The following is a description of a gene set: studied in species Homo sapiens from publication Chen Y, Wang X (PMID 31504780) Genes predicted to be targets of miRBase v22 microRNA hsa-miR-1208 in miRDB v6.0 with MirTarget v4 prediction scores > 80 (high confidence targets). Human Gene Set: MIR1208, and this is the list of marker genes: POLR1F, TMED6, ADD3, CHMP2B (charged multivesicular body protein 2B), GRIA4, BTBD3, PRKAB1, YTHDF2, IRS2, PAQR9 (progestin and adipoQ receptor family member 9), IL5RA, FNDC3A, PPP1R10, PPP2R2A, ZFR, AFF3, SECISBP2L, BACH2, OXR1, BTBD10, LINC03040, GPM6B, DISC1, ZKSCAN1, ZC3H13, HERPUD2, GNB4, IRF6, ZIC3, TYR, TMEM170B, PACSIN2, HAPSTR1, ZDHHC7, ROBO2 (NCBI Gene Id 90370), CRTAP, NUDCD1, NFATC3, BCLAF3, ADRA1A, AP1G1, FANCA, JKAMP, ZNF280D, CDADC1 (cytidine and dCMP deaminase domain containing 1), USP45, TCEAL4, HIC2, CNTRL, SLC24A2, SRSF10, DHFR2, GORASP1, CASP14, ARHGEF6, SLC25A44, AGPAT4, TMEM209, SPRY3, EIF2S2, KIF3A, TBX1, PABPC3, AEBP2, GPR180, LDHA, GANC, CXXC5, PDIK1L (PDLIM1 interacting kinase 1 like), CHN1, LEPROT, ZBTB22, ZNF592, DNAJC21, MYCBP2, VBP1, TUSC1, MCFD2 (multiple coagulation factor deficiency 2, ER cargo receptor complex subunit), INO80D, LCOR, ZNF461, CDC27, TRIP12, NUCKS1, PDE3A, KRTAP7-1, RUFY2, TMPRSS2, WDFY3, TIMM17A, SMCO3, SRC, SIPA1L2, SORBS2, ARMCX1, DHFR, ADAM12, DMXL1, ST8SIA2, NFAT5, ZEB1, FGFR1, SPATA20, PDE7B, TLE4, LRP6, PTPRG, PLCXD3, SLC35B1, RNF145, GMCL1, PHF21A (PHD finger protein 21A), IL7R, SRSF3, SCFD1, PALS2, MGAT4A, BAZ2B, CDH19, NT5C1B-RDH14, NXF5, EPOP, FCHSD2, UTP23, DENND1B, MBNL3, LRRN1 (leucine rich repeat neuronal 1), DR1, ERC2, GLUD1, MRPL13, CNTNAP3, SYPL2, CNTNAP3B, CCDC178, CYBRD1, PDIA6